The following is a description of a gene set: Genes predicted to be targets of miRBase v22 microRNA hsa-miR-6737-3p in miRDB v6.0 with MirTarget v4 prediction scores > 80 (high confidence targets). Human Gene Set: MIR6737_3P studied in species Homo sapiens from publication Chen Y, Wang X (PMID 31504780), and this is the list of marker genes: FKBP10, KLHDC10, NUDT5, UBN2, IER5, SRCIN1 (NCBI Gene Id 80725), ATP10A, MARCHF4, KLF12, ATXN2, VPS13A, MGAT4A, C18orf63, APOB, DPF1, DTNA, SCAI, MED23, NRK, FEM1A, ZNF267, RIMS1, ACAD10, ZNF518A, TOP2B, ESAM (endothelial cell adhesion molecule), ZZZ3, SLC9A6, RHBDL3, CALN1, USP31, KCNQ4, BCL3, PDAP1, RASSF5, BBIP1, FGFRL1, PALM2AKAP2, CLCN5, SKIL, PLEKHF2, LRIG1, FAM229A, NKAPD1, TIAL1, MMP24, YEATS4, MBD6, C11orf58, CCDC32, ZNF33A, RAB8B, PLGRKT, TMF1, ADAMTS3, CHD6, MAT1A, PALLD, POU2F1, COA5, TUBG1, PCGF2, CADM2, SDC2, LALBA, ZNF704, LIMCH1, ETS2, CEP85L, BICD1, NRBP1, EPB41L5, HECTD1, GRIP1, OGT, GSG1, AP2A1, KANSL1, DIDO1, CARD17P, ANKRD44, DICER1, ZNF275 (NCBI Gene Id 286459), CNDP1, CDC6, RAB5IF, DYNC1I2, MAST4, AGL, GSK3B, CA2, ALDH5A1, ZNF831, CYP2U1, PUM2, CEP350, MBNL1, PCDH17, COL6A5, SPRED1, ADCY5, MYLIP, TMEM187, SLC1A2, ACADSB, FAM53A, TAB3 (TGF-beta activated kinase 1 (MAP3K7) binding protein 3), YY1, SCN4B, C11orf87, GPAM, RAD23B, MEA1, CXXC5, MECP2, FAM78A, FHOD3, DDO, CHMP2B, BCHE, TENM3 (NCBI Gene Id 55996), CLK3, NCAM1, LIFR, BIVM, PHTF2, PHF13 (NCBI Gene Id 148479), TTC39C, SAMD12, FGF14, ARK2N, PSME4 (proteasome activator subunit 4), RAB7B, COL4A4, TLCD4, DCAF10 (NCBI Gene Id 80211), ZFAND5, HEXIM1, APLP2, EIF3H, POC1B, DDX6, WWP1, HIVEP3, TRARG1, AS3MT, PYHIN1, SLC35F1, FIGNL1, USF2, SLC1A4, SLC11A2, FGF12, NAT8L, NAMPT, FAM219A, PCDH8, WDR47, STAU1, TMEM132B, SLC38A1, VIRMA, ZDHHC2, RICTOR, TSPAN7, SP4, SORCS1, KLF9, JCHAIN, SLC39A1, SLITRK6, AHRR, FOXN3, PECAM1 (platelet and endothelial cell adhesion molecule 1), ZDHHC11, DDX5, CELF5, TOX3, TULP3, ZFHX3 (NCBI Gene Id 463), TAC1, B3GAT1, EGFR, ZMYND10, WDR3, LMNB1, ELK4, MIER3, PACS1, ERRFI1, KCNF1, STK35, UPRT, PAN3, SPIRE1